The following is a description of a gene set: Signaling by EGFR in Cancer Human Gene Set: REACTOME_SIGNALING_BY_EGFR_IN_CANCER species: Homo sapiens, and this is the list of marker genes: NRAS, PIK3CA, RPS27A, UBA52, UBC, EREG, BTC, KRAS, HBEGF, EPGN, CDC37, GRB2, HSP90AA1, PIK3R1, PLCG1, HRAS, CBL, EGF, TGFA, EGFR, AREG, SOS1, SHC1, UBB, GAB1